Given this list of marker genes AGPAT2, CIDEC, LEP, LIPE, LEPR, LMNA, AKT2, BANF1, BSCL2, KCNJ6, ZMPSTE24, here is a description of the gene set: Human Gene Set: HP_DECREASED_SERUM_LEPTIN Decreased serum leptin species: Homo sapiens A decreased concentration of leptin in the blood.